The following is a description of a gene set: Broad clavicles Human Gene Set: HP_BROAD_CLAVICLES studied in species Homo sapiens Increased width (cross-sectional diameter) of the clavicles., and this is the list of marker genes: ATP7A, PTH1R, WNT7A (NCBI Gene Id 7476), PTDSS1, MYSM1, SOST, TRIP11, SH3PXD2B, MMP14, ARSK, MMP2